Given this list of marker genes CCL11, TMOD2, RCC2, DOCK1, CDK5RAP2, HCFC1, PIK3R1, PTEN, POC1B, HAX1, SCFD1, SPAG5, WNT3A, MCIDAS, LIMK2, MAPRE1, ARAP1, LRRTM2, FZD5, PFN2, RAC2, RHOQ, FAM107A, ARPC5L, BRCA1, MAPK15, PATL2, TGFBR1, RPS6, GPM6A, P2RY12 (purinergic receptor P2Y12), PRUNE1, METTL18, PRKCH, CAPZA1 (capping actin protein of muscle Z-line subunit alpha 1), WASL, SYNPO2L, IQSEC2, BIN3, TFIP11, KAT2B, CEP120, EPHA1, CHEK2 (NCBI Gene Id 11200), NPHP4, MMP14, THY1, RB1, CLASP1, EPHB1, CCN2 (NCBI Gene Id 1490), RAP2A, RHOG, HAUS4, MEFV, CARD8, GFAP, S100A10, C15orf62, RHOC (ras homolog family member C), ATP8B1, HTT, MAPK9, CRMP1, UBAP2L, ENPP7, TOGARAM1, TPPP3, MIR98, IAPP, SLAIN1, RTN4, PIP4K2B, BAG5, INTU, NCLN, CAPZB, EPB41L5, LRRK2, XRCC5, AGT, KDR (NCBI Gene Id 3791), CCL24, BAIAP2L1, TNF, MYO3A, PIP4K2C, IFNB1, CDC42EP3, NUMBL, BID, CAMSAP1 (calmodulin regulated spectrin associated protein 1), SDC4, SLC12A5, SLK, ATMIN, TMOD4, UBE2M, TMOD1, HOPX, ECT2, TUBB4A, TBC1D13, LRSAM1, SLITRK6, LINGO2, PTPRJ, CEP97, NUP62, CCL26, PLD1, RASA1, EPHA7, INPP5K, CDKL1, ODF2, MIR20A, ARPC2, RHOA, BRCC3, TRIM47, CTTN (NCBI Gene Id 2017), IL1RAP, PAQR4, CHMP5, H3-3B, NLGN3, MNS1, PRKCD, F11R, SPHK2, TMEFF2, ERCC1, NOTO, COBL, ATR, NDEL1, RPS3, MEF2C, ABI3, RHPN2, SSH3, ULK1, EHMT2, IRX3, DAAM2, HSPA8, UBLCP1, VPS8 (NCBI Gene Id 23355), STYXL1, PAN3, YAP1, DDX3X, WAS, COLQ, TPM1, ABHD8, WNT4, KCNK13, CCN1, HRG, ROCK1, DCDC2, SORBS3, FRMD7, WASF2, BCL11A, SLX1B, KANK2, CDC42EP2, TENM2, NCKAP1 (NCK associated protein 1), FNBP1L, RAB3GAP2, SNX9, ISG15, RABGAP1, FAM98A, KCTD17, PLK1, ST8SIA2, NCKIPSD (NCK interacting protein with SH3 domain), LRRN1, CRYAB, SAMD8, NRG1, DNAJA4, ANLN, WASHC2C, SLITRK5, DKK1, KAT2A, HCLS1, CLIP1 (NCBI Gene Id 6249), CDH17, BRK1 (BRICK1 subunit of SCAR/WAVE actin nucleating complex), ACE, NF2, CAPRIN1, SDCCAG8, MMP1 (matrix metallopeptidase 1), ZDHHC1, RASIP1, STX1A, GIT1, PPM1F, TWF1, NECTIN3, KLF5, RAB3GAP1, ARMCX5-GPRASP2, EVI5L, SYNE2, SPHK1, CDKL5, MALSU1, SEPTIN8, IFT140, VLDLR (NCBI Gene Id 7436), BRSK1, CORO2B, ISL1, STUB1, SPTBN2, P2RX4, SHANK3, LRRTM1, PRKAA1, CAMSAP3, SPTA1, CYFIP1, TBC1D7, RCC1, RAB11FIP3, SRC, MIR21, APP, JMJD6 (jumonji domain containing 6, arginine demethylase and lysine hydroxylase), CTNNBIP1, HAUS5, CCR7, MYOC, RAB11A, VPS41, ZNF750, MARK2, TPPP, PDZD11, P2RX7, WIPI1, PLPPR5 (NCBI Gene Id 163404), NLGN4X, LCP1, PODXL, DSG3, PIK3CA, HRK, VPS35, WDPCP, PLCE1, AKIRIN1, ASIC2, IFT88, LHFPL4, GDI2, NOTCH1, C9orf72, ASAP3 (ArfGAP with SH3 domain, ankyrin repeat and PH domain 3), DUT, PPP2CA (protein phosphatase 2 catalytic subunit alpha), MDM1, MAPT, NEDD8, PLCG2, CAMSAP2, ACTG1, GAP43, PPP1R9B, USP16, SNX18, CLSTN1, ARHGAP6, FERMT2, WNT7A, SNAI1, CNOT6L, HRAS, HJURP, AMIGO2, ATP13A2, EML3, TBC1D16, DNAJC6, ODAD3, PAK2, ARHGEF18, LRTM2, TBC1D22A, ZDHHC12, LRP4, HIP1R, MDGA1 (MAM domain containing glycosylphosphatidylinositol anchor 1), ABI2, VPS16, NUDT16, IKBKE, UBQLN2, CNTNAP2, PAK3, CX3CL1, ATM, DYRK1A, MIR138-1, WASHC1, AKAP9, CFL1, NTRK1, RIPOR2 (NCBI Gene Id 9750), LCMT1, VIL1, LZTS1, SHANK1, OPRD1, FUZ, CGNL1, LRFN1, NLRC3, GREM1, DNAJB8, LRFN5, RAC1, ZDHHC5, CDH5, THBS2, CCDC15, EPS8L3, CLRN1, TGFB3, TMEM39A, HDAC6, BMF, CD47, EIF4G1, COTL1, EPS8L1, ELMO1, EIF2AK2, CHMP4B, PTPRS, CHMP6, CNOT2, ARHGEF10L, PDCD6IP, SAXO1, HAUS3, SIRT3, MAP4, ACTR2, SENP6, TLR2, SKAP1, TTBK2, KIF9, TBCD, MIR27B, BBC3, MARK1, FLII, DYNC1H1, EVI5, SOX9, SYNGR3, DUSP22, RPL13A, MYD88, MIR145, BBS4, SNAI2, DLC1, POLDIP2, RALB, SLAIN2, PUM2, LMO4, EPHB2, SIX1, UNC13B, GNA13, ARHGEF15, ARHGAP12, ARHGAP44, WNT1, IL1B, LIMK1, DNAJB6, RAPGEF3, NBDY, MECP2, MTMR3 (NCBI Gene Id 8897), ACTR3, WRAP73, SKA1, GPR65, VPS33A, PREB, MTPN, MAVS, CYLD, ROCK2, TP53, STXBP5, BIRC2, RP1, SH3GLB1, VEGFA, GPC4, CHGA, PHLDB2, LDB2, ATG2A (autophagy related 2A), PTPN1, LIMA1, TRABD2B, SMAD3, SASS6 (NCBI Gene Id 163786), SDCBP, BECN1, ADGRB1, MMP3, STMN1, TPR, CLEC7A, PLEKHM1, SLITRK1, MARK4, JAM3, MIR17, TPBG, TWF2, NTNG2, BAIAP2L2, NPM1, TERF1, MTM1, RTN4R, NCKAP1L (NCK associated protein 1 like), FLNA, STX18, ICE1, ARF6, EEF2K (eukaryotic elongation factor 2 kinase), MIR19B1, KANK4, ICAM5, PLEKHG2, ARHGAP40, BMP7, GPSM2, TBC1D2B, CEP295NL, PRKCZ, DAPK3, CDC42EP1, LMOD3, PSMC6, GHSR, AGRN, LIMCH1, ABL1, HAUS7, OCLN, CUX2, NEGR1, GHRL, SDC1, NLGN1, KCNK6, ANKRA2, NCK1, MYO1C, CNOT6, MIR105-1, HAUS2, AKAIN1, STXBP1, INPP5J, PYDC1, TBC1D22B, LMOD2, MARCHF7, SLC39A12, MIR18A (microRNA 18a), SNX4, CHRNB2, PTPN22, TCHP, MAK, CHD4, CAPG, NTN1, PFN1, FCHSD1, KIF14, SPTBN4 (NCBI Gene Id 80322, spectrin beta, non-erythrocytic 4), ORMDL1, VILL, NEK7, ANKRD27, CAPZA3, TBC1D21, AIDA, MAP2, ADD3, AJUBA, MIR149, TREM2, EZR, RAPGEF2, RBM14, TJP1, TENM1, LATS2, SYP, TBC1D10B, ENTR1, PIP4K2A, CROCC, EP300, SLITRK4, CDK5R1, DUSP3, SPTBN1, VPS11, CHMP4C, TMC8, SCIN, ABCA3, ARPC3, MYO10, ATAT1, TRIOBP, GBA1, DEF8, RACK1, SETD5, ARL2, STIL, FBXL2, PLA2G6, TBC1D20, AMBRA1, GNL3L, CARMIL1, FAM110C, APC, CDC42, FER, PTK2, MKKS, HAUS6, NRXN2, VCP, CARMIL3, NAE1, LGALS3, SENP1, TBC1D14 (TBC1 domain family member 14), SEMA4C, MSTN, CRB3, ABCA2, LDB1, TBC1D1, ZNF827, LAMP2, HYAL1, NTRK2, ODF2L, CLDN5, NUPR1, CNTROB, SRGAP2B, THRA, SAR1A (secretion associated Ras related GTPase 1A), KIF24, FLRT2, USP50, CEP135, LIN7A, PEAK1, TERF2, PYDC2, SNF8, CAND1 (cullin associated and neddylation dissociated 1), SYNPO2, PPFIA1, MAPRE3, TACSTD2 (NCBI Gene Id 4070), HCK, EPHB3, CDC42EP4, ALOX15, TIRAP, IFI16, ZMYND10, FARP2 (NCBI Gene Id 9855), LATS1, VPS39, LINGO4, VSTM5, IRGM, WDR45, SMPD3, ARF4, RNF4, CLSTN2, IGSF11, TRABD2A, TBC1D8, AMIGO3, NUMA1, HAS3, IL5, SPTB, ZMYND8, RAPGEF1, H3-3A, HAUS8 (NCBI Gene Id 93323), PTPRA, WARS1, OSBPL2, STMP1, SEMA4A, SWAP70, SLITRK2, FERMT1, CTNNB1, MIR214, AMOT, PRKCA, MIEN1, PTPRD, TNFSF18, IKBKB, FBLIM1, CHMP1A, SH3YL1, SIX4, MIR9-1, PEX5, HSP90AA1, CSF2, NPHS1, STMN2, APLNR, NOP53, ADNP, ORMDL2, HAP1, CCP110, SLX4, MYCBP2, BIK, ADGRB2, HSPA5, TSC1, PDLIM5, SVIP, FSCN1, RAB17, SNCA, SUMO1, DOCK4, MED25, TGFBRAP1, USP6NL, ASB2, PIK3R2, IFT20, TBC1D15, RALA, IL17A, SGSM3, HNRNPU, CAV1, STAP1 (signal transducing adaptor family member 1), PRKACA, CYFIP2, CLIP3, VCL, MACF1, MAP4K4, DOCK10, CAV3, GSK3B, VPS4B, SSH1, BIN1, BAX, TBX5, RAB7A, CHMP2A, CDK10, EPS8, TLN1, RDX, PPP1R35, RAB5A, DLG1, PRKD1, SYK, SRF, ELN, KIF21A, GBP2, STAU2, MTSS1, BTK, NLGN2, TMOD3, NR1H2, PLK2, CRIPT, BCL2L11, FGFR1, NRXN1, MPHOSPH9, PPARG, SLITRK3, ACE2, TPPP2, SRGAP2, FEZ1, CLSTN3, SIGMAR1, PAN2, CYRIA, SNX7, MUSK, PHF23 (NCBI Gene Id 79142), TFRC, S1PR1, SLF1, DPYSL3 (dihydropyrimidinase like 3), CBLN1, SYNDIG1 (synapse differentiation inducing 1), WDR44 (NCBI Gene Id 54521), HTR4, PALM, PTGER4, ZDHHC8, MSN, SNCAIP, CORO1A, IL1RAPL2, TBC1D19, MET, CLASP2, FKBP4, SVIL, PPP1R16B, BAK1, CKAP5, ADGRB3, CARMIL2, RICTOR, PRICKLE1, SEPTIN9, HSPA1B, GRB2, BDNF, CD36, C10orf90, PREX1, PSRC1, TTC8, CHMP7, ANTXR1, CAPZA2, LRFN3 (leucine rich repeat and fibronectin type III domain containing 3), SLF2, ADD2, VPS4A, OAZ3, MIR483, RAP1B, TRAF3IP1, TRAPPC12, RHPN1, SNX30, NLRP2B, FLRT1, ADAMTS16, WNT5A, AVIL, MYADM, DYNC2LI1, GDF2, RAB3IP, CASKIN1, LUZP1, TACR1, FCHSD2, PPP2CB, TGFBR3, CRTAC1, ROBO2, PXN, CRBN, TBC1D2, ARPC5, NAPA, TICAM1, HAS2, F2RL1, LRFN4, EFNB1, CRACD (capping protein inhibiting regulator of actin dynamics), TBC1D9B, APOD, USP10, EMILIN1, CSNK1A1, CHMP4BP1, OGT, CHMP3, SFRP1, ACVRL1, ABCB7, RNF5, NME7, DZIP1, SLX1A, CCSAP, PAK1, CENPJ, ITGB1BP1, VPS18, MIR431, DAB2IP, HAUS1, CPTP, ESAM, TRIM37, TTBK1, FLOT1 (NCBI Gene Id 10211), PIKFYVE, EPHA2, STAM, CHMP2B, FMR1 (NCBI Gene Id 5421), USP17L2 (NCBI Gene Id 392198), MIR219A1, TAPT1, TMSB4X, SIRT2, SPTAN1, EML2, SPICE1, CCL19, CHMP4A, FLRT3, SORL1, SELP, AUTS2, PDE4DIP, ORMDL3, SYNPO, LMOD1, FES, LIN7B (NCBI Gene Id 64130), NECTIN1, DNAJC15, TRPM2, ARHGAP35, CBLN2, HGS, RAP1GAP, PTK2B, ICAM1, OXT, FHOD1, CORO1C, TSG101, RAF1, ADD1, STXBP6, CNOT1, TAL1, NPHP1, HSF1, SEMA4D, DMTN, TEK, RGCC, TRIM31, SEPTIN7, SLIT1, SSH2, ATG5, TBC1D3, MTLN, TRIM11, IFNG, CSF3, GPM6B, CXCL13, EFNA5, HES1, PINK1, ABITRAM, PTPN11, DNAJB2, MIR29B1, REST, HSPA1A, FNIP1, MIR196A1, UBE3B, PLEK2, CCL21, CHMP1B, SERPINF2, FNIP2 (folliculin interacting protein 2), TBC1D30, MLST8, CLU, ARHGEF9, DYNLT2B, LRRC24 (NCBI Gene Id 441381), BRAF, CDKN1B, SLIT2, TLR6, SMAD4, NAV3, RAB1B, PLXNB3, DACT1, KIT, TRIM32 (NCBI Gene Id 3971), SOST, RAP1A, CREB1, GPBAR1, TRAF2, GAK, MPP7, LIMS1, NRP1, WNT10B, DLG5, COL16A1, PTPN13, SEC22B, SRGAP2C, DCTN1, DOCK11, FEZ2 (fasciculation and elongation protein zeta 2), GRID2, CLN3, SAR1B, THBS1, LRRTM3, PYCARD, ELAPOR1, APOE, PLEK, ABCA1, ASIC1, PRKN, BBS10, INSM1, GSN, VASP, TLR4, ARHGAP28, SEC16A, APOA1, EVL, FZD1, TBC1D10A, ATG3, BAG4, HSPA2, MOAP1 (NCBI Gene Id 64112), BAIAP2, KIRREL1, RABEP2, SRPX2, MAP1B, MARCHF5, ARHGAP24, PPP2R5B, CEP295, CC2D1A, GBA2, HMGB1, KANK3, CCDC88A, MIR142, GPRASP3, SACS, NTRK3, ARHGAP18, TAC1, PRRT2, TESK1, RHPN2P1, EPS8L2, DRG1, LRRN3, TBC1D10C, FARP1, SPTBN5, PPM1E (protein phosphatase, Mg2+/Mn2+ dependent 1E), PYDC5, TBC1D5, LPAR1, ABHD17A, PFN3, MAPK8, LRRC4B, ARHGEF7, SPIDR, EPHA3, TGFB1, MIR19A (microRNA 19a), AKT1, RIOK3, CYRIB, RNF186, MYO3B, LCAT, NEURL1, CEP76 (NCBI Gene Id 79959), ARHGEF10, DHX33, RHOD, PSMC5, DNAJB1, TBC1D24 (NCBI Gene Id 57465), PIEZO1, ARHGEF5, SLC9A1, CLDN1, PLK4, GBP5, ARHGAP33, RAC3, SMCR8, MIR144, ANKRD53, TBC1D17, ARFGEF1, RBM10, AMIGO1, LIN7C, NCK2, RTEL1, IL1RAPL1, NAPB, KANK1, CDK2, PRKAA2, TBC1D12, PRKCE, MTOR, CDC42EP5, TRIM65, ALMS1, STX1B, PARK7, TIE1, S1PR2, here is a description of the gene set: studied in species Homo sapiens Human Gene Set: GOBP_REGULATION_OF_CELLULAR_COMPONENT_BIOGENESIS Any process that modulates the frequency, rate or extent of cellular component biogenesis, a process that results in the biosynthesis of constituent macromolecules, assembly, and arrangement of constituent parts of a cellular component.